The following is a description of a gene set: Mouse Gene Set: GOBP_NEGATIVE_REGULATION_OF_EPITHELIAL_CELL_DIFFERENTIATION_INVOLVED_IN_KIDNEY_DEVELOPMENT Any process that stops, prevents or reduces the frequency, rate or extent of epithelial cell differentiation involved in kidney development. species: Mus musculus, and this is the list of marker genes: Mmp9, Osr1, Cited1, Sall1, Stat1, Ctnnb1